Given this list of marker genes Cnot6l, Bmp2k, Mtor, Adgrb3, Fign, Ash1l (NCBI Gene Id 352974), Stk17b, Ube2g1, Rapgef4, Spin1, Foxq1, Ankrd27, Fut9, Phactr4, Ppbp, Mitf, Ttyh3, Pbx2, Galr1, Tarbp1, Ntn4, Cbfa2t3, Ppp3r1, Gdnf, Pmepa1, Rab3c, Tcf7l2, Bcl2l12, Chst10 (NCBI Gene Id 98595), Dcun1d1, Lrig1, Lrrc58, Usp5, Camsap2, Rev1, Slc6a9, Morf4l1, Tmem198, Cdc42bpg, Sdc2, Oxsr1, Dgkk, Med1, Irs1 (insulin receptor substrate 1), Lrrc28, Rbm20, Gfm2, Foxo4, Celsr1 (NCBI Gene Id 57075), Zfc3h1, Stx5a, Zfand5, Tc2n, Gcnt1, Gpr21, Tnfrsf1b, Gria1, Rab8b, E2f5, Zyg11b, Pard3b, Arpc5l, Dab1, Foxk2, Yipf4, Cnn3, Atxn3, Kpnb1, Fundc2, Fam168a, Plppr4, Dlat, Yipf6, Dnaaf9, Ccdc121rt2, Spast, Hbegf, Snx16, Ptp4a1, Slc7a8, Foxf2, Tut4, Mtcl2, Fem1b, Sox5, Prrt3, Nova2, Ctdsp1 (NCBI Gene Id 227292), Clock, Coro1c, Xkr4, Tmem170b, Map2k1, Brms1l, Prdm16, Arpp19, Dcaf10, Tns3, Wdr82, Tac1, Riox1, Ppp1r9b, Iqsec1, Ostm1, Olfm1, Zfhx4, Prtg, Il12a, Chic1, Adcy6, Gng12, Lnx2, Cnot9, Slc16a9, Ell, Brwd1, Umad1 (NCBI Gene Id 100036521), Nlgn2, Grb2, Vamp3 (vesicle-associated membrane protein 3), Foxo1, Grhl2, Slc1a1, Uck2 (uridine-cytidine kinase 2), Plekhm1, Rundc3b, Fndc3b, St8sia3, Spen, Nus1, Anxa11, Lrch2, Gnai3, Bcr, Rnf139, Hook3, Ogt, Inpp5a, Abhd18, Kdm6a, Stmnd1, Gpc3, Dock1, Prrx1, Cacnb4 (calcium channel, voltage-dependent, beta 4 subunit), Sh3kbp1, Galnt2, St6galnac3, Tet1, Ccdc121rt3, Spsb1, Cpeb1, Adgra2, Pnpla8, Snx30, Frs2, Usf3, Cyrib, Myrip, Farp1, Ralgps1, Zfp449, Magel2 (MAGE family member L2), Eif3j2, Ppp4r3a, Col25a1, Slc12a5, Rictor, Vangl2, Cdh20, Rab23, Elavl4 (ELAV like RNA binding protein 4), Rab2a, Bltp2, Abcd1, Chst1, Hsf5, Ankib1, Prrg3, Wipi2 (WD repeat domain, phosphoinositide interacting 2), Ccdc89, Prkce, Zfp961, Reps2, Lgi1, Fam171a1, Nexmif, Gpr22, Tmem145, Zhx2, Palld, Epha3, Cacna2d2, Vat1l, Gabrb1, Phf20l1 (PHD finger protein 20-like 1), Alk, Ints8, Plod2, Trib3, Unc13c, Phaf1, Sox6, Ncald, Phyhipl, Taf4b, Zbtb41, Hoxa9, Add3, Meox2, Aqp5, Sh3pxd2b, Slco3a1, Map2k3, Ahr, Rarg, Mtss1 (NCBI Gene Id 70087), Arhgap24, B4galnt1, Hacd4, Dgkh, Slc12a6, Or51ab3, Atg9a, Lmtk2, Gad2, Klhl4, Jmjd1c, Cd164, Neurod4 (neurogenic differentiation 4), Cttn, Tbl1x, Arsj, Insig2, Sinhcaf, Lcp1, Lrrc3, Cep83, Rhpn2, Dpy19l3, Casp2, Arf2, Stag1, Nptx2, Cnnm3, Tes, Tsku, Slc44a2, Tgfbr1, Kif19a, Zeb1 (NCBI Gene Id 73165), Bsdc1, Arhgef3, Nudt13, Sort1, Frmd5, Rassf8, Slc39a1, Eif5, Ebf3, Brpf3 (bromodomain and PHD finger containing, 3), Igf2bp1, Ezr, Mak, Zfp36l1, Pde8b, Ube2q2, Slf2, Klhl7, Zcchc3, Has2, Hsd3b5, Slain2, Fbxo41, Gulp1, Reck, Gp1bb, Cep170b, Zkscan17, Eif4ebp2, Itpr2, Nptx1, Phip, Ap3s1, Pappa, Adam28 (a disintegrin and metallopeptidase domain 28), Sh3bp5, Lamc1, Cep97, Rasa1, Nanos1, Rps6ka6, Ywhag, Nup50, Epb41l3, Nsg1, Slc22a5, Zhx1, Atxn1, Serpinb2, Prkar1a, Cntn1, Lmtk3, Dock4, Tbr1, here is a description of the gene set: Mouse Gene Set: MIR_1271_5P Genes predicted to be targets of miRBase v22 microRNA mmu_miR_1271_5p in miRDB v6.0 with MirTarget v4 prediction scores > 80 (high confidence targets). studied in species Mus musculus from publication Chen Y, Wang X (PMID 31504780)